The following is a description of a gene set: Any process that activates or increases the frequency, rate or extent of programmed cell death, cell death resulting from activation of endogenous cellular processes. Human Gene Set: GOBP_POSITIVE_REGULATION_OF_PROGRAMMED_CELL_DEATH species: Homo sapiens, and this is the list of marker genes: CTNNB1, PDCD1, TNFRSF10A, PSEN1, TLE5, NTRK3, CCN1, TMEM164, IGFBP3, BARD1 (BRCA1 associated RING domain 1), HLA-G, PDCD5, ING4, DDIT3, HMGB1, BMPR1B, P2RX7, MFN2, BCL10, QRICH1, GADD45G, CASP9, EIF2S1, NEUROD1, ARG1, MEF2C, CD248, TP53BP2 (tumor protein p53 binding protein 2), CASP7, GSN, DDX3X, WWOX, PIK3CB, APP, MIR15A, CAPN10, EIF2B5, MSX1, CLIP3, PRKN, SOD1, MIR140, JAK2, POMC, PRDM11, RASSF2, SLC9A1, TLR6, TNFSF14, EEF1A2, C3orf38, CASP2 (caspase 2), SOX4, ALDH1A2, RPS3, UBD, RASSF6, MSX2, ARHGEF7, MTCH2, PRR7, LGALS2, NOX1, F2RL1, ITGB1, MIR98, NOTCH2, FASLG, MIR15B, S100B, TRAF2, DUSP6, DDX20, ANXA1, CD274, NOS1, BAG1, UBE2Z, MIR137, PNMA2, RBCK1, GRN, NOTCH1, LRRK2, TNFSF15, TGFB1, B4GALT1, PRF1, CASP3, BIN1, PTRH2, TCTN3 (NCBI Gene Id 26123), JUN, INHBA, DAPK2, ITGA1, TNFSF10, USP17L24, CASP6, ING5, BBC3, MIR200B, IL20RA, DHCR7, BACE1, SIAH1, ERCC3, LTK, STK4, FLCN, STK3, GPER1, RBM10, CTSC, LTA, BCAP31, SNCA, THBS1, CDK5R1, OLFM1, HSPD1, TFPT, PLAGL2 (NCBI Gene Id 5326), ADAM8, HSF1, TNFRSF1A, TP53BP1, HRG, XBP1, IRF8, TNFRSF10C, ATP2A2, CAV1, VDR, PPP2R1B, VNN1, PLA2R1, HYAL2, TSC22D1, TNFSF12, TOP2A, CASP4, PPID, FOXO1, RYBP, TNFRSF1B, HSPA9, G0S2, PIAS4, MIR146A, ZNF268, MIR451A, PANO1, CDKN2A, CTLA4, TAF6, GPLD1, FBXW7 (NCBI Gene Id 55294), PPP2R1A, HMOX1, DDX19A, RBM5, ST8SIA2, AIFM1, CDK5, PTPN2, WT1, PLCG1, TNFAIP8, NTSR1, PITX3, PEA15, MAP3K20, BID, MIR29B1 (NCBI Gene Id 407024), RRP1B, RARG, NGFR, MAPK9, MNDA, GADD45B, CAMK2D, MIR24-1, BECN1, VDAC1, DNM2, DUSP1, TNFRSF8, HCAR2, PIK3CD, DAPK1, RAPGEF2, TPD52L1, MIR29C, RHOB, TLR3, IRF5, PHB1, LATS2, INHBB, DNAJA1, EEF1E1, BAK1, MIR195, SOD2, KNG1, RNF183, NOD1, AIMP2, RNF122, DFFA, APBB2, IFNG, HDAC3, TRADD, TMEM196, MAP3K9, LGALS16, GRIN2A, MYBBP1A, SLC27A4, PDCD4, GSK3A, PTPA, ITM2C, HTATIP2, CD40LG, SP1, TRIM39, ANKRD1, NR3C1, TGFB2, BCL6, GSK3B, LATS1, RNPS1, STYXL1, SAP18, ATM, ECSCR, ITGA4, ADORA2A, CCL2, MIR125A, ACIN1, LCN2, SPHK2, DEDD2, TEX261, CRADD, ZC3H8, KCNMA1, PNMA3, POU4F2, PLEKHN1, MIR103A1, CFLAR, PAK2, LTB, AGT (NCBI Gene Id 183), MIR221, ATG7, CCAR2, SKIL, ACVR1C, BMP2, ATF4 (NCBI Gene Id 468), MAP3K10, PRMT2, PRELID1, BCL2A1, BTG1, NCK2, MIR17, DIABLO, SLIT2, TIGAR, MIR132, MIR29A, PML, BAD, PERP, IL6, NLRC4, F2R, PNMA1, ID3, SIRT2, EI24, UNC5C, PRKRA, F3, FNIP1, CAMK2A, PDCD6, CCL3, IFNB1, TRIM35, FANK1, PAWR, PNMA5, LEP, EMILIN1, ABL1, RIPK1, BNIP3, PRKDC, IDO1, NCOA1, CCAR1, DCUN1D3, NEURL1 (neuralized E3 ubiquitin protein ligase 1), HTT, ANO6, TBX20, MAP3K11, AKR1C3, USP27X, AGTR2, PHLDA3, SFRP4, BOK, MIR375, TFAP2B, STUB1, WNT11, IP6K2, MIR19B1, GRIK2 (NCBI Gene Id 2898), AKAP12, BCL2L11, STK17B, HOXA13 (homeobox A13), PIDD1, ZNF622, CYP1B1, TSPO, UTP11 (UTP11 small subunit processome component), SCIN, RIPK3, RACK1, PHLDA2, MIR200A, MIR27A, MMP2, ISL1, STPG1, BCL2L1, TGFB3, DNAJA3, IAPP, FAF1, WNT10B, FAM162A, CDK19, FBH1, LGALS9, TGM2, ADAMTSL4, FCAR, BMF, SAV1, MIR1-1, FAS, NDUFA13, ADCY10, CASP10, PARK7, LCK, ENDOG, BAX, MIR210, TGFBR1, E2F3, SPDEF, FADD, FRZB (NCBI Gene Id 2487), SIK1, PCSK9, MIR204, CASP8, CREB1, FAP, LILRB1, MCL1, SRPK2, MIR101-1, TP63, RPL26 (ribosomal protein L26), ZBP1, PDCD2, DAB2IP, MIR27B, ITGA6, CSRNP3, PTPN1 (protein tyrosine phosphatase non-receptor type 1), NF1, MIR4516, NR4A1, PMAIP1, MELK, NR4A3, CRYBA1, UNC13B, MIR92A1, INCA1, NKX3-1, HTRA4, PTPRC, MAPK8, EPHA7, BCLAF1, RAPSN, TFAP2A, LPAR1, SMPD1, PPP1CA, TNF, OMA1, CIDEB, TNFRSF12A, GADD45A (growth arrest and DNA damage inducible alpha), SMAD4, ECT2, IL12A, APC, ZBTB16, TMC8, NHERF1, CERS6, SERINC3, GRAMD4, PARP1, NFATC4, RGCC, ALDH1A3, E2F1, TNFSF11, BMP4 (NCBI Gene Id 652), CTNNA1 (catenin alpha 1), FOXA1, SYCE3, MAP3K5, CD40, IL10, MIR28, SFPQ (NCBI Gene Id 6421), PTGIS, GZMA, JMY, LAPTM5, CYLD (NCBI Gene Id 8010), CAMK1D, HTR2A, SFRP2, MIR34A, RIPK2, CDKN1A, ARL6IP5, MAL, CARM1, CTSD, BCL2L2, ITPR1, INPP5D, NTRK1, S100A9, RAD9A, MIR26B, BLID, S100A8 (S100 calcium binding protein A8), ATF3, CAPN2, PDIA3, IL19, TLR4, MYB, NET1, TXNIP, BCL2L14, BMP7, GAL, REST, CCL5, HTRA1, STK17A, KATNB1, IFIT2, C1QBP, ASCL1, TP73, CD160, DKKL1, PRNP, MIR449A, MLLT11, MIR16-1, BCL2L10 (NCBI Gene Id 10017), FIS1, MIR23A, SEPTIN4, RPS6, BRMS1, PRKCI, MIR107, ADIPOQ, ZSWIM2, ZC3H12A, LYN, SQSTM1, LGALS1, HOXA5, PHLDA1, IGF2R, BCL2, FOXO3, MIR181B1, MTCH1, NLRP2B, MYCN, MIR21, CASP12, TP53, CTNNBL1, CLU, SCRIB, NUPR1, KLF11, PRKCD, CALHM2, EMILIN2, HRK, TIA1, POU4F1, TP53INP1, GSDME, RET, RPS7, PIP5KL1, EIF5A, TFAP4, ATF6, TNFRSF10B, MAGED1 (NCBI Gene Id 9500), PPARG, HPGD, MYC, RPS6KA2, MMP9 (matrix metallopeptidase 9), DAPK3, MARK4, CTSH, SIRT1, MOAP1, MIR186, APBB1, TRAF7, PYCARD, CASP14, FOXP1, MIR675, SRPX, DLC1, PLA2G1B, FZD9, MIR320A, CASP5, RARB, CHEK2, BNIP3L (BCL2 interacting protein 3 like), AIFM2, NCK1, IL12B, APAF1, NACC2, FOXL2, HTRA2, SFRP1, LTBR, CXCR3, WNT5A, UBB